The following is a description of a gene set: Binding to a ferric iron ion, Fe(III). species: Mus musculus Mouse Gene Set: GOMF_FERRIC_IRON_BINDING, and this is the list of marker genes: Ftdc1, Fthl17c, Ftl2-ps, Trf, Fthl17e, Fthl17d, Rrm2, Fthl17f, Fthl17a, Miox, Acp5 (NCBI Gene Id 11433), Ftmt, Th, Ftl1, Fxn, Fthl17b, Ftdc2, Fth1